Given this list of marker genes GNG3, GNG5, TIRAP, TYK2, GNA13, GNAI1, GNB4, GNG8, CNR2, GNAZ, GNAT1, GNB1, JAK2, GNG14, GNAO1, TRAF6, GNG5B, JAK3, GNAI3, GNB2, GNA12, GNG2, GNG12, GNG10, MYD88, TGM3, GNAI2, GNAL, GNA15, GNGT1, GNGT2, MCF2L, GNG11, DTNA, GNB3, GNB5, GNA11, GNA14, GNG7, CARMIL2, GNAQ, GNAS (GNAS complex locus), PLEKHA4, GNAT3, GNG4, GNAT2, JAK1, GNG13, TRAF3IP2, here is a description of the gene set: species: Homo sapiens Human Gene Set: GOCC_EXTRINSIC_COMPONENT_OF_CYTOPLASMIC_SIDE_OF_PLASMA_MEMBRANE The component of a plasma membrane consisting of gene products and protein complexes that are loosely bound to its cytoplasmic surface, but not integrated into the hydrophobic region.